The following is a description of a gene set: species: Homo sapiens A histone reader that recognizes a histone H3 trimethylated at lysine 9. In some organisms, there is only H3K9me2, not H3K9me3, but this modification is recognized by homologous readers. Human Gene Set: GOMF_HISTONE_H3K9ME2_3_READER_ACTIVITY, and this is the list of marker genes: UHRF2, PHF13, DPPA3, FGF2, BRD3, CBX2, RRP8 (ribosomal RNA processing 8), MPHOSPH8, CBX5, HDGFL2, UHRF1, CDY1, DPF2, ATRX, SUZ12, CDY1B, CDYL2